The following is a description of a gene set: Any process that decreases the rate, frequency or extent of granulocyte chemotaxis. Granulocyte chemotaxis is the movement of a granulocyte in response to an external stimulus. Human Gene Set: GOBP_NEGATIVE_REGULATION_OF_GRANULOCYTE_CHEMOTAXIS studied in species Homo sapiens, and this is the list of marker genes: TNFAIP6, C5AR2, MIR223, DPP4, SLIT2